The following is a description of a gene set: from publication Chen Y, Wang X (PMID 31504780) studied in species Homo sapiens Genes predicted to be targets of miRBase v22 microRNA hsa-miR-571 in miRDB v6.0 with MirTarget v4 prediction scores > 80 (high confidence targets). Human Gene Set: MIR571, and this is the list of marker genes: LMX1A (NCBI Gene Id 4009), STRN, RFPL1, MTRF1 (NCBI Gene Id 9617), IL6R, MFSD6, STK11IP, MEMO1, SAMD12, RNF169, PAX8 (NCBI Gene Id 7849), FAM163A, RDH12, ZBTB42, CREBRF, RUNX1, TXK, NECAB1, PIM1, KCNIP1, PPP1R12B (protein phosphatase 1 regulatory subunit 12B), XDH, RABGAP1L, POU2F3, RFPL3, SS18L2, CREBBP, REG1A, KCNH7, KCNN3, SLC1A6, SPAG8, CSNK2A1, RANBP10, DMBT1, RASSF8, CHD1, RAB9A, ZNF426, BIRC3, HECW1, MRPS18B (mitochondrial ribosomal protein S18B), ATP5MK, ITGA6, GPC6, ERLIN2, ANKIB1, GLG1, XPO1, TNFSF8, LAMA1, KIAA1328, PIK3CG, PAPOLA (NCBI Gene Id 84718), CYP24A1, CLIC2, SLC6A4, OTUD3, RGPD1, KDM5B, H2BC5, TRAPPC4, SCRT2, FBXW10B, FLVCR2, LINGO1